Given this list of marker genes RBBP4, ADIPOR2, GLUL, HM13, PHETA2, CDC42SE1, ZNF566, BCL2L14, CCNQ, SNX1, CPT2, CBX4, MYO7A, KLHL9, WEE1, GALK2, OPRL1, RPA2, DTL, MRPS15, TEC, PLEKHA1, MKNK2, MAP4K4, F7 (coagulation factor VII), GNPDA1, CD99L2, SYT17, RNH1, FAM98C, MTFMT, PANX1, AUH, TTC4, PLPP2, HLA-DMA, NAT9, HDAC6, MYO5A, C19orf12, ATE1, WASHC2A, SRP14, ZNF703, SEC16A, CDC20, CWC27, ELP2, PNPLA6, SKP1, ADCY7, FBLIM1, DGLUCY, ATM, DESI1, ATP6V0A2, GINS1, LGALS4, HEXIM1, MAD1L1, AP2S1, TUBA1A, CRCP, STK10, HMG20A, PIGH, SLC25A45, NME2, FKBP4 (FKBP prolyl isomerase 4), DGKZ, MVB12B (NCBI Gene Id 89853), CUTA, PRPF3, GSDME, ARCN1, TMEM115, SERHL2, PLA2G15, GPATCH4, BRINP1, AGL, NUDT3, NDUFA10, TFEB, HMGCL, CENPA, C1D, HAT1 (NCBI Gene Id 8520), FBXO9, GASK1B, SVIL, HEATR1, PINK1, CPSF1, ITM2B, MTMR1, PTDSS1, GATC, PLIN3, AGPAT3, ERBB3, MGST2, IER3IP1, LAMB3, FAM117A, CTNS, SLC25A20, LCLAT1, LUC7L3, BLOC1S5, DFFA, SLAMF8, RPL14, C19orf48P, ANAPC2, SF3B2, ALAD, INPP4A, RAB31, YIPF7, RPS6KA3, UGP2, MRPL34, TMPRSS4, CDCA3, CLNS1A, DDX39B, TXNL4A, CETN2, EVI5, ANKS1A, RNASE4, RERE, CNGB3, RAB28, C14orf119, COG6, MEF2D, RUVBL1, SYNPO, STRBP, MIDN, TBCD, PLEKHF1, MLLT10, WFS1, MFAP1, RPS21, WDR45, CDK2, EMILIN1, NUCB2 (nucleobindin 2), NEK1, TUBA1B, MGAT4B, PDXK, TREH, CLDN10, XPR1, MRI1, GALC, PDLIM2, TESK2, ABCB7, PAG1, SLC7A7, EPS15, SIRT3, USP20, DAB2, RBL2, MRPL36, ELMO2, ZKSCAN3, SLC29A3, FAM111A, FAM193B, PRXL2C, RERG, ADD1, PAK1 (NCBI Gene Id 5058), CDKAL1, TTC28, TRIM39, CTDSP1, MPP3, SPEG, CHKA, AQR, GYS1, GOLM1, CC2D1A, STRN4, CPSF4, MDP1, BTBD1, NGRN, ANKMY2, SIDT2, FKBP7 (NCBI Gene Id 51661), here is a description of the gene set: from publication Amit I, Garber M, Chevrier N, Leite AP, Donner Y, Eisenhaure T, Guttman M, Grenier JK, Li W, Zuk O, Schubert LA, Birditt B, Shay T, Goren A, Zhang X, Smith Z, Deering R, McDonald RC, Cabili M, Bernstein BE, Rinn JL, Meissner A, Root DE, Hacohen N, Regev A (PMID 19729616) Genes up-regulated in comparison of control dendritic cells (DC) at 4 h versus those stimulated with Gardiquimod (TLR7 agonist) at 4 h. Human Gene Set: GSE17721_CTRL_VS_GARDIQUIMOD_4H_BMDC_UP studied in species Homo sapiens mouse primary BMDCs were stimulated with tlr ligands and gene expression changes were profiled on Affymetrix arrays